The following is a description of a gene set: species: Mus musculus PPAR gamma is an adipocyte-specific nuclear hormone receptor. Agonists of PPAR gamma, such as thiazolidinediones (TZDs), promote adipocyte differentiation and have insulin-sensitizing effects in animals and diabetic patients. Affymetrix oligonucleotide arrays representing genes were employed to profile the gene expression responses of mature 3T3-L1 adipocytes and differentiating preadipocytes to a TZD PPAR gamma agonist in vitro. The expression of genes was significantly up- or down-regulated by more than 1.5-fold during differentiation and/or by treatment with TZD, and these genes were organized into 32 clusters that demonstrated concerted changes in expression of genes controlling cell growth or lipid metabolism. Quantitative PCR was employed to further characterize gene expression and led to the identification of beta-catenin as a new PPAR gamma target gene. Both mRNA and protein levels for beta-catenin were down-regulated in 3T3-L1 adipocytes compared with fibroblasts and were further decreased by treatment of adipocytes with PPAR gamma agonists. Treatment of db/db mice with a PPAR gamma agonist also resulted in reduction of beta-catenin mRNA levels in adipose tissue. These results suggest that beta-catenin plays an important role in the regulation of adipogenesis. Thus, the transcriptional patterns revealed in this study further the understanding of adipogenesis process and the function of PPAR gamma activation. Selected genes up-regulated during differentiation of 3T3-L1 cells (fibroblast) into adipocytes in response to adipogenic hormones. from publication Gerhold DL, Liu F, Jiang G, Li Z, Xu J, Lu M, Sachs JR, Bagchi A, Fridman A, Holder DJ, Doebber TW, Berger J, Elbrecht A, Moller DE, Zhang BB (PMID 12021175) Human Gene Set: GERHOLD_ADIPOGENESIS_UP, and this is the list of marker genes: ACADVL, GCLM, BCKDHA, ALDH2, SCD, PMP22, CD36, PPARG, GPX4, GADD45A, ACSL1, CFD, COX8A, MCL1, LDHB, FASN, CEBPB, STAT3, FABP5, CPT2, FABP4, PLIN2, SPARCL1, VEGFB, PDHA1, VLDLR, LIPE, VEGFA, PC, ADRB3, ACADS, CIDEC (NCBI Gene Id 63924), APOE (NCBI Gene Id 99), ANAPC1, STAT1, MNT, AGT, LDHA, ITGA7, PPA1, ADIPOQ, DDIT3, CRAT, STAT5A, SCP2, SQSTM1, GHR, IGF1